The following is a description of a gene set: In the absence of Hh signaling, the majority of full-length GLI3 is partially processed by the proteasome to a shorter form that serves as the principal repressor of Hh target genes. Processing depends on phosphorylation at 6 sites by PKA, which primes the protein for subsequent phosphorylation at adjacent sites by CK1 and GSK3. The hyperphosphorylated protein is then a direct target for betaTrCP-dependent ubiquitination and proteasome-dependent processing. part of: Hedgehog 'off' state Reactome Pathway: GLI3 is processed to GLI3R by the proteasome studied in species Homo sapiens, and this is the list of marker genes: RBX1, PSMD1 (proteasome 26S subunit, non-ATPase 1), PSMB7, BTRC, PRKACB, PSMD6, PSMB1, UBA52, PSMB5, PSMA3, PSMB4 (NCBI Gene Id 5692), PSMD12, PSMC1, PSMD13, PSMB3, PSMD7, PSMB6, PSMC3, SKP1, PSMD2, PSMC5, CUL1, PSMA1, PSMD11, PSMA5, UBC, PSMD8, GSK3B, PSMC4, ADRM1, PSMA4, SEM1, PSMC2, PSMC6, CSNK1A1, PSMD3 (NCBI Gene Id 94019), PSMD14, PSMA6, RPS27A, PRKACA, PSMA7, PSMB2, PSMA2, SUFU, GLI3, UBB, PRKACG